Given this list of marker genes RPP38, POP5 (POP5 homolog, ribonuclease P/MRP subunit), POP1, POP7, RPP25, RPP40, RPP25L, RPP30, POP4, here is a description of the gene set: A ribonucleoprotein complex that contains an RNA molecule of the snoRNA family, and cleaves the rRNA precursor as part of rRNA transcript processing. It also has other roles: In S. cerevisiae it is involved in cell cycle-regulated degradation of daughter cell-specific mRNAs, while in mammalian cells it also enters the mitochondria and processes RNAs to create RNA primers for DNA replication. Human Gene Set: GOCC_RIBONUCLEASE_MRP_COMPLEX species: Homo sapiens